The following is a description of a gene set: Human Gene Set: GOBP_CONSTITUTIVE_HETEROCHROMATIN_FORMATION species: Homo sapiens The compaction of chromatin into heterochromatin, a conformation that is refractory to transcription. Constitutive heterochromatin cannot be converted back to euchromatin, the transcriptionally-active conformation. In metazoa, this involves the methylation of histone H3K9., and this is the list of marker genes: EHMT2, H3-3B, KMT2A, MBD3L2, MBD3L5, HDAC1, ATF7IP, BEND3, TDRD9, DOT1L, ATRX, MPHOSPH8, MBD3, H3-3A, TDRD5, TDRD12, EZH1, PPHLN1, L3MBTL1, TEX15, HAT1, PIWIL4, TDRD1, DNMT1, DNMT3A, RESF1, PIWIL2, MAEL, SETDB1, SMYD5, TRIM28, MBD2, SIRT6, PIWIL1, MORC2, SIRT2, MBD1, BMI1, MBD3L4, TASOR, MBD3L1, SPIN1, EZH2, MBD3L2B, XIST, ZNF304, MORC1, FKBP6, RIF1, MOV10L1 (Mov10 like RNA helicase 1), SMARCA5, SPOCD1, MBD3L3, DDX4, EHMT1, CTCF, PPM1D, BAZ2A, DNMT3L, CENPV (NCBI Gene Id 201161), HELLS, C19orf84, SIRT1